Given this list of marker genes COL4A5, COL1A2, COL1A1, TLL1, TLL2, LOX, COL4A1, COL4A3, LOXL1, COL4A6, PXDN, COL4A2, COL4A4 (collagen type IV alpha 4 chain), LOXL2, PCOLCE, BMP1, LOXL4, LOXL3, here is a description of the gene set: Reactome Pathway: Crosslinking of collagen fibrils part of: Assembly of collagen fibrils and other multimeric structures species: Homo sapiens After removal of the N- and C-procollagen propeptides, fibrillar collagen molecules aggregate into microfibrillar arrays, stabilized by covalent intermolecular cross-links. These depend on the oxidative deamination of specific lysine or hydroxylysine residues in the telopeptide region by lysyl oxidase (LOX) with the subsequent spontaneous formation of covalent intermolecular cross-links (Pinnell & Martin 1968, Siegel et al. 1970, 1974, Maki 2009, Nishioka et al. 2012). Hydroxylysine is formed intracellularly by lysine hydroxylases (LH). There are different forms of LH responsible for hydroxylation of helical and telopeptide lysines (Royce & Barnes 1985, Knott et al.1997, Takaluoma et al. 2007, Myllyla 2007). The chemistry of the cross-links formed depends on whether lysines or hydroxylysines are present in the telopeptides, which depends on the proportion of collagen lysines post-translationally converted to hydroxylysine by LH. The lysine pathway predominates in adult skin, cornea and sclera while the hydroxylysine pathway occurs primarily in bone, cartilage, ligament, tendons, embryonic skin and most connective tissues. Oxidative deamination of lysine or hydroxylysine residues by LOX generates the allysine and hydroxyallysine aldehydes respectively. These can spontaneously react with either another aldehyde to form an aldol condensation product (intramolecular cross-link), or with an unmodified lysine or hydroxylysine residue to form intermolecular cross-links.<br><br>The pathway of cross-linking is regulated primarily by the hydroxylation pattern of telopeptide and triple-helix domain lysine residues. When lysine residues are the source of aldehydes formed by lysyl oxidase the allysine cross-linking pathway leads to the formation of aldimine cross-links (Eyre & Wu 2005). These are stable at physiological conditions but readily cleaved at acid pH or elevated temperature. When hydroxylysine residues are the source of aldehydes formed by lysyl oxidase the hydroxyallysine cross-linking pathway leads to the formation of more stable ketoimine cross-links. <br><br>Telopeptide lysine residues can be converted by LOX to allysine, which can react with a helical hydroxylysine residue forming the lysine aldehyde aldimine cross-link dehydro hydroxylysino norleucine (deHHLNL) (Bailey & Peach 1968, Eyre et al. 2008). If the telopeptide residue is hydroxylysine, the hydroxyallysine formed by LOX can react with a helical hydroxylysine forming the Schiff base, which spontaneously undergoes an Amadori rearrangement resulting in the ketoimine cross link hydroxylysino 5 ketonorleucine (HLKNL). This stable cross-link is formed in tissues where telopeptide residues are predominanly hydroxylated, such as foetal bone and cartilage, accounting for the relative insolubility of collagen from these tissues. In bone, telopeptide hydroxyallysines can react with the epsilon-amino group of a helical lysine (Robins & Bailey 1975). The resulting Schiff base undergoes Amadori rearrangement to form lysino-hydroxynorleucine (LHNL). An alternative mechanism of maturation of ketoimine cross-links has been reported in cartilage leading to the formation of arginoline. <br><br>These divalent crosslinks greatly diminish as connective tissues mature, due to further spontaneous reactions (Bailey & Shimokomaki 1971, Robins & Bailey 1973) with neighbouring peptides that result in tri- and tetrafunctional cross-links. In mature tissues collagen cross-links are predominantly trivalent. The most common are pyridinoline or 3-hydroxypyridinium cross-links, namely hydroxylysyl-pyridinoline (HL-Pyr) and lysyl-pyridinoline (L-Pyr) cross-links. HL-Pyr is formed from three hydroxylysine residues, HLKNL plus a further hydroxyallysine. It predominates in highly hydroxylated collagens such as type II collagen in cartilage. L-Pyr is formed from two hydroxylysines and a lysine, LKNL plus a further hydroxyallysine, found mostly in calcified tissues. Trivalent collagen cross-links can also form as pyrroles, either Lysyl-Pyrrole (L-Pyrrole) or hydroxylysyl-pyrrole (HL-Pyrrole), respectively formed when LKNL or HLKNL react with allysine. A further three-way crosslink can form when DeH-HLNL reacts with histidine to form histidino-hydroxylysinonorleucine (HHL), found in skin and cornea. This can react with an additional lysine to form the tetrafunctional cross-link histidinohydroxymerodesmosine. <br> <br>Another mechanism which could be involved in the cross-linking of collagen IV networks is the sulfilimine bond, catalyzed by peroxidasin, an enzyme found in basement membrane.<br><br>To improve clarity inter-chain cross-linking is represented here for Collagen type I only. Although the formation of each type of cross-link is represented here as an independent event, the partial and random nature of lysine hydroxylation and subsequent lysyl oxidation means that any combination of these cross-linking events could occur within the same collagen fibril.